The following is a description of a gene set: studied in species Homo sapiens Human Gene Set: HP_ABNORMAL_NONVERBAL_COMMUNICATIVE_BEHAVIOR Abnormalities in eye contact, communicative facial expressions, gesture use, or the use of others' bodies to communicate convey shared meanings within a culture that replace or supplement verbal communication. Abnormal nonverbal communicative behavior, and this is the list of marker genes: IREB2, TMEM163, WWOX, MEF2C, NEUROD2, SPEN, ADCY5, DOCK7, CAMK2B, PIGA, ARFGEF2, SHANK3, DLK1, GABRA2, MYT1L, NDUFB10, NEXMIF, ATP1A2, MT-ND1, SMC1A, CNTNAP1, GUF1, NDUFA6, ARX, NDUFAF4, AGTPBP1, NHLRC2, PIGP, SLC25A12, NDUFS1, NDUFA11, UBA5, MT-ND3, GLS, NTNG1, NDUFC2, AP3B2 (NCBI Gene Id 8120), NDUFS8, MFF, CHD8, MT-ND2, NLGN3, CUX2, NALCN, NDUFA1, ITPR1, GNB5 (NCBI Gene Id 82962), AFG2A, KCNT1, NTRK2, ST3GAL3, CACNA2D2, RARS1, ADNP, TMEM126B, NDUFAF2, TARS2, FOXRED1, NDUFS7, NDUFS3, UGP2, GABBR2, CNTNAP2, GRIA3, NDUFB9, ADSL, MECP2, NDUFB11, POLA1, NDUFAF3, NDUFAF5, NDUFA13, NUBPL, NDUFV1, NDUFV2, NDUFAF1, NLGN4X, PUF60, TIMMDC1, SPTBN1, MEG3, TRIM8, FLCN, NDUFS4, NDUFS6, KMT5B, RTL1, GRIN1, GRIN2B, DOLK, SLC25A1, CDKL5, MBD5, MICOS13, ALG2, GFM1, FRMPD4, FMR1, RAB11B, NDUFS2, OPHN1, ALG13, SYT1, SNRPN, GFM2, TBC1D23, NDE1, ADAM22 (NCBI Gene Id 53616), CLP1, GALNT2, SLC13A5, TWNK, GPHN, NDUFB3, DEAF1, COX10, FOXG1, NDUFAF8, MDH2